Given this list of marker genes Tusc2, Trem3, Pcyox1l, Myd88, F2, F2rl1, Dao, Ctsg, Cxcl5, Trem1, Nlrp6, Scnn1b, Elane, Ncf1, here is a description of the gene set: The directed killing of a bacterium by a neutrophil. Mouse Gene Set: GOBP_NEUTROPHIL_MEDIATED_KILLING_OF_BACTERIUM studied in species Mus musculus